Given this list of marker genes IL6ST, JAK2, CNTFR, IL11RA (NCBI Gene Id 3590), LIF, IL31, TYK2, JAK1, OSMR (NCBI Gene Id 9180), CTF1, IL11 (interleukin 11), OSM, CLCF1, LIFR, IL31RA, CNTF, CRLF1 (cytokine receptor like factor 1), here is a description of the gene set: studied in species Homo sapiens part of: Interleukin-6 family signaling Reactome Pathway: IL-6-type cytokine receptor ligand interactions The members involved in (interleukin)-6-type cytokine signalling are the IL-6, IL-11, LIF (leukaemia inhibitory factor), OSM (oncostatin M), ciliary neurotrophic factor (CNTF), cardiotrophin-1 (CTF1) and cardiotrophin-like cytokine factor 1 (CLCF1). Receptors involved in recognition of the IL-6-type cytokines can be subdivided in the non-signalling alpha-receptors (IL6R, IL 11R, and CNTFR) and the signal transducing receptors (gp130, LIFR, and OSMR). The latter associate with JAKs and become tyrosine phosphorylated in response to cytokine stimulation. IL27 and IL35 belongs to IL12 cytokine family but they share gp130 as a component of signalling receptor, along with IL-6, IL-11, LIF, OSM, CNTF, CTF1 and CLCF1.